The following is a description of a gene set: species: Homo sapiens part of: Diseases of branched-chain amino acid catabolism Mutations in AUH are associated with 3-methylglutaconic aciduria, a rare autosomal recessive disorder. AUH catalyzes the fifth step in the catabolism of leucine, the conversion of 3-methylglutaconyl-CoA to 3-hydroxy-methylglutaryl-CoA. Mutations that affect AUH stability or function result in accumulation of metabolic intermediates such as 3-methylglutaconic acid, 3-methylglutaric acid and 3-hydroxyisovaleric acid that are excreted in urine. The clinical presentation of 3-methylglutaconic aciduria is variable ranging from no-to-mild symptoms to severe encephalopathy, metabolic acidosis and coma. Reactome Pathway: 3-methylglutaconic aciduria, and this is the list of marker genes: AUH